The following is a description of a gene set: The chemical reactions and pathways resulting in the formation of adenosine monophosphate (AMP) from inosine 5'-monophosphate (IMP). species: Mus musculus Mouse Gene Set: GOBP_DE_NOVO_AMP_BIOSYNTHETIC_PROCESS, and this is the list of marker genes: Gart, Atic, Ppat, Adsl, Adss2, Paics, Adss1, Pfas